The following is a description of a gene set: Pathway Definition from KEGG: IGG -> FCGR -> CRK -> DOCK1 -> RAC Human Gene Set: KEGG_MEDICUS_REFERENCE_IGG_FCGR_RAC_SIGNALING_PATHWAY IGG-FCGR-RAC signaling pathway. Pathway ID: N01090. Pathway type: Reference. Pathway class: nt06135 Cytoskeletal regulation (viruses and bacteria). species: Homo sapiens, and this is the list of marker genes: ENSG00000275063 (NCBI Gene Id 102723407), RAC3, FCGR3A, RAC2, FCGR3B (Fc gamma receptor IIIb), RAC1, DOCK1, CRK, FCGR2A, FCGR1A